The following is a description of a gene set: from publication Chen Y, Wang X (PMID 31504780) Human Gene Set: MIR6810_3P Genes predicted to be targets of miRBase v22 microRNA hsa-miR-6810-3p in miRDB v6.0 with MirTarget v4 prediction scores > 80 (high confidence targets). studied in species Homo sapiens, and this is the list of marker genes: TMEM202, PCBP4, OXER1, BTG1, ZNF268, FBRS, AVL9, GIGYF1 (NCBI Gene Id 64599), PTPN2, ALKBH7, ASB1, CHD8, CHST11, KLF16, ICOSLG, TSLP, DNMT3B, PLSCR3, GAB2, SNPH, MICOS10, AKT3, SHROOM4, C19orf44, SYBU, CLPP, PMEPA1, CDADC1, DIS3L2, WSB1, SNX8, SLC6A6, SEMA7A, MDN1, OTX2, PHAF1, SLC9A1, ZBTB2, EPC2, ZNF652, FBXW11, FAM78B, C2CD4C, ZNF37A, ZNF442, ZNF823, GFOD1, GPAT4, RABGEF1, GRHL1, MIER3, KMT2D, BLZF1, TBC1D16, KDM5B, ADGRG6, TBC1D9B, RIMS3, DIP2B, PXDC1, LOXL3, FAM131B, NACC1, SENP3, NRP2, ARRDC5, ZNF74, DST, NAGPA, RBFA, NUP210L, ITGA3, JADE2, PTGFRN